Given this list of marker genes RAD51AP1, CENPA, EZH2, PCNA, PCLAF, RACGAP1, HJURP, CDCA3, H2AX, HMMR, CKS1B (NCBI Gene Id 88475), GINS2, ESPL1, CENPE, MKI67, KIF20A, HMGB2, SHCBP1, CCNA2, FOXM1, BIRC5, CKS2, CDCA8, PRIM1, ZWINT, MCM4, GMNN, CDK1, RFC4, E2F8 (NCBI Gene Id 79733), MCM6, SMC2, CCNB2, NDC80, ASPM, RFC3, FANCI, KIF4A (kinesin family member 4A), MCM3 (minichromosome maintenance complex component 3), AURKA, TOP2A, KIF18B, NUSAP1, UBE2C, NCAPG, MCM7, PRC1, CENPF, RRM2, KIF14, RRM1, TYMS, ASF1B, NCAPD2, PLK1, TPX2, DLGAP5, MT1JP, CDC20, MCM2, KIF11, MELK, BUB1B, FEN1, TTK, TMPO, SMC4, AURKB, here is a description of the gene set: Neighborhood of CCNA2 cyclin A2 in the GNF2 expression compendium Human Gene Set: GNF2_CCNA2 studied in species Homo sapiens Neighborhood of CCNA2